Given this list of marker genes MAGT1, WAS, FAS, IL2RA, FASLG, CASP10, COG6, here is a description of the gene set: Decreased specific anti-polysaccharide antibody level Human Gene Set: HP_DECREASED_SPECIFIC_ANTI_POLYSACCHARIDE_ANTIBODY_LEVEL The presence of normal overall immunoglobulin levels with deficiency of specific immunoglobulins directed against bacterial polysaccharides. studied in species Homo sapiens